The following is a description of a gene set: Abnormal internal genitalia studied in species Homo sapiens An anomaly of the adnexa, uterus, and vagina (in female) or seminal tract and prostate (in male). Human Gene Set: HP_ABNORMAL_INTERNAL_GENITALIA, and this is the list of marker genes: MINPP1, FZD2, PIK3CA, STAT6, TMEM270, RTEL1, IL12A, BAZ1B, IL17RD, RAD51, CYP11A1, NDNF, DKC1, NHP2, CLDN2 (NCBI Gene Id 9075), POR, CDKN1C, CDKN2A, IPO8, PRKN, ARID1B, HYLS1, PHKG2, PI4KA, SPRED1, DYNC2LI1, MYRF, CHD7, NCF1, RELA (RELA proto-oncogene, NF-kB subunit), HOXD13, LMNB2, CCNQ, FGFR2, AARS1, DYNC2I1, MDM2, BRCA1, GREB1L, MBD4 (NCBI Gene Id 8930), UBAC2, RNASEL, ELN, FLI1, H19, POLR1B, TGFBR2, SLC9A3, GNRHR, MSH2, TBX4, ZFPM2, RAD51C, CDC73, WDPCP, HDAC8, DMRT1, HARS2, PALB2, PIGG, RREB1, BSCL2, FREM1, HGD, TGFB3, PHF6, FIGLA, HFE, LZTFL1, BUD23, MSH4, SEMA3A, BBS7, ARL6, CORIN (NCBI Gene Id 10699), F7, ANTXR2 (NCBI Gene Id 118429), NR0B1, VPS37D, ZFHX3, PHKB, CC2D2A, FLRT3, KCNN4, NBN, PDE11A, NSD2 (nuclear receptor binding SET domain protein 2), APC, ZSWIM7, RECQL4, KIF7, BRIP1, SDHB, CYP17A1, PLAAT3, PMS1, BRCA2, GTF2E2, PTPN12, COL5A2, IL17F, SCLT1, PMS2, KEAP1, SRCAP, STAT4, PTCH2, KLRC4, MPLKIP, SMC3, THOC6, PLG, CAPN15, PROKR2, ESR1, GLI1, IL10RB, PTPN22, TNXB, WRN, FGF10, PTPRJ, TERC, DLC1, CLPP, DNAJC30, SPECC1L, GCLC, FLCN, JAK3, CHEK2, CAV1, LETM1, IL17RC, SOX10, GNB2, RAD54B, BMPR1B, NRAS, PHGDH, CREBBP, TRPV6, EWSR1, PDGFRL, DCTN4, POLR1C, TBX3, BBS4, ADGRG2, MLH1, ADH5, ARVCF, COL1A1, NOBOX, PRKAR1A, WNT7A, TCTN3, BUB1B, RAD51D, RSPO2, TLR4, ERCC3, OPCML, MXI1, MCC, HES7, NAB2, TAC3, NDP, ITGA8, CAVIN1, CFTR, BBS5, IDH1, GREM1, SEMA4A, POLR1D, FANCL, WNT7B, PPP2R3C, LONP1, TLR2, SLC11A1, BRD4, FANCB, IFT80, TTC8, LYN, ERAL1, HPS6, FKBP6, DACT1, BTK (NCBI Gene Id 695), GATA4, GRIP1, NR5A1, STAG3, SMAD3, FGF8, UBR1, GTF2IRD2, CYB5A, TGFB2, HLA-B, HSD17B4, WNT4 (NCBI Gene Id 54361), IGKC, CDH1, TBL2, COL5A1, RFWD3, IFNGR1, WNT10A, SPRY4, PAX6, RPS6KA3, AURKA (aurora kinase A, NCBI Gene Id 8465), EPHB2, DYNC2I2, SDCCAG8, ITPR1, COL3A1, PARN, PATL2, CCR1, PPP2R1A, EDNRA, FANCF, CFAP418, AXIN2, SMC1A, COL7A1, PTPN11, MRE11 (NCBI Gene Id 4361), STX1A, MRPS22, TYMS, USF3, KISS1, CEACAM6 (CEA cell adhesion molecule 6), TGFB1, IL17RA, DIS3L2, ESCO2, MSH5, COMT (catechol-O-methyltransferase), MESP2, CTBP1 (C-terminal binding protein 1), LHB, DICER1, TUBB8, SRC, GTF2I, KLF6, FRAS1 (NCBI Gene Id 84949), CTLA4 (cytotoxic T-lymphocyte associated protein 4), CBX2, GNAS, KRAS, FGFRL1, ARHGAP31, HFM1, IL23R, VAMP7, FANCC, PLIN1, SEC24C, NIPBL, TERT, PPARG, KCNQ1, TP53, TACR3, WEE2, SLC6A14, SMAD4, CEP57, INSR, BBS1, GPC3, HS6ST1, GTF2IRD1, TSC2, MKS1 (MKS transition zone complex subunit 1), GTF2H5, AKT2, HMOX1, IRF6, HROB, CEP19, RET, TGFBR1, STOX1, LRP2, AAGAB, TSC1, HLA-DPA1, RABL3, DCC, SCAPER, RNF113A, EP300, REST, GSTM3, SLX4, KISS1R, LEPR (NCBI Gene Id 3953), PLA2G2A, MAD1L1, SF3B4, UFD1, PMM2, CEACAM3, BBS9, CYP11B1, BARD1, HNF1A, AGPAT2, PIGN, GLI3, TAF6, LIMK1, FANCE (NCBI Gene Id 2178), MMP2, ZEB2, SLC37A4 (NCBI Gene Id 84965), PALLD, TRIM32, RXYLT1, ERCC2, GATA3, EVC, RFC2, IL10, STK11, SOX11, CIDEC, RPS20, COL14A1, BMPR1A, SEC23B, DUSP6, RNU12, KLLN, BUB1, UBE2T, OFD1, C4A, FH, PROK2, RIPK4, MSX1, MIF, BAX, SLC34A2, MID1, KIF14, DHH, ALMS1, COX7B, CLEC7A, HNF1B, KCNQ1OT1, PRLR, FLT1, GATA2, FEZF1, RNF43 (ring finger protein 43), IFT74, NIN, B3GLCT, BBS2, MSH3, MAP3K1, LFNG, ANOS1, FANCI (FA complementation group I), IGHG2, MEFV, ZFTA, C14orf39, TBX6, FOS (NCBI Gene Id 2353), COL4A5, HIRA (histone cell cycle regulator), IFT172, METTL27, DHCR7, BBS12, SUFU, TRAIP, PAX3, FGF20, NF2, PRTN3, TBX1, PPP1R12A, PSMC3IP (NCBI Gene Id 51769), SALL1, CTNNB1, NHLH2, GFRA1, WWOX, FSHR, POU6F2, SDHD, FOXE1, MMP14, HESX1, ERAP1, CCND1, STRA6, BNC1, BUB3, ALG9, EPCAM, WNT3, PTEN, LMNA, HCCS, MAD2L2, FANCG, DLL3, SLC26A9, SMAD2, NSMF, COL4A6, RAD50, PSMB8, SETBP1, SEMA3E, BRAF, NTHL1, FOXL2, CLIP2, WDR35, MNX1 (NCBI Gene Id 7987), BBIP1, SERPINA1, DDB1, MTM1, POLE, ERCC4, MSH6, LZTR1, CTC1, CEP290, HLA-DPB1, IGF2, AR, ERCC6, MUTYH, POLD1, LARS2, POLR3H, TRAF3IP2, PRKACA, FGF17, NOP10 (NOP10 ribonucleoprotein), BMP15, MKKS, NR2F2, IL12A-AS1, ATM, WRAP53, ZPR1, TRIM28, JMJD1C, RBM8A, SDHC, HOXA13, TOE1, SALL4, SPIDR, SOX3, NPM1, CCDC141, PIK3R1, TP63, USB1, EIF4H, FANCA, FANCD2, CCDC28B, PANX1, SOX9, RARB, PTCH1, VHL, INTU, SMARCB1, TCOF1, WT1, SOHLH1, NDUFB11, RIPPLY2, RAD21, FREM2, BCOR, SPINT2, CARS1, GNRH1, TWNK, EFEMP1, UNG, XRCC2, SETD2, LIPE, IFT27, SLC6A17, TXNDC15, NUP107, MCM8, MT-CYB, SRY, SLC35A2, FANCM, DYNC2H1, EVC2, TARS1, CHRM3, COQ6, FGFR1, AKT1, TRIP13, DHX37, LEP, CPLX1, IDH2, WNT9B, ZMYM2, BBS10, MAMLD1, AXIN1, FGFR3, NELFA, TINF2, FOXF1, NPHP1, GP1BB, MYC, CYP19A1, CLCA4, MLH3, DCAF17, ERBB2, SRD5A2, WDR11, CDKN1B, FAS (NCBI Gene Id 355), PRKACB, CXCR4, PHKA2